Given this list of marker genes Cyp8b1, here is a description of the gene set: species: Mus musculus This event has been computationally inferred from an event that has been demonstrated in another species.<p>The inference is based on the homology mapping from PANTHER. Briefly, reactions for which all involved PhysicalEntities (in input, output and catalyst) have a mapped orthologue/paralogue (for complexes at least 75% of components must have a mapping) are inferred to the other species. Reactome Pathway: Sterols are 12-hydroxylated by CYP8B1 electronically inferred by orthology from the curated human pathway part of: Endogenous sterols